The following is a description of a gene set: Human Gene Set: HP_BLOODY_DIARRHEA Passage of many stools containing blood. species: Homo sapiens Bloody diarrhea, and this is the list of marker genes: KIF23, CDKN1A, COX15, WIPF1, SMAD4, TGFB1, SI, CYP7B1, SKIC3, RBCK1, BMPR1A, SHARPIN, SKIC2, ENG, STK11 (NCBI Gene Id 6794), PTEN, RACGAP1, GREM1, GP1BB, IL37, ACVRL1, F8, ITGA2, CARD8, EGFR, GP1BA, SREBF1, ATRX, CDKN1B, CDKN2B, TTC7A (NCBI Gene Id 57217), F9, IFIH1, CD109, ITGB3, ARPC1B, AMACR (alpha-methylacyl-CoA racemase), WAS, HPS1, MEN1, APC, IL10RA, FAH, ARPC5, ADAM17, ITGA2B, PI4KA, TAOK1, F5, CDKN2C, PLVAP